The following is a description of a gene set: Mouse Gene Set: GOBP_RNA_5_END_PROCESSING species: Mus musculus Any process involved in forming the mature 5' end of an RNA molecule., and this is the list of marker genes: Rnmt, Ncbp3, Ncbp1, Rpp38, Pop4, Prorp, Pop5, Thg1l, Nop9, Ramac (RNA guanine-7 methyltransferase activating subunit), Rpp30, Ssb, Pop1, Cmtr1, Cmtr2, Rpp40, Rpp14, Trmt10c, Abt1, Pnpt1, Tbl3, Tgs1, Pop7, Rpp25l, Rngtt, Rpp21, Hsd17b10, Rpp25